Given this list of marker genes MAP3K7, IRAK4, MAPK1, IKBKB, PLCG1, NFKBIA, PELI1, CHUK, TAB2, IL1B (interleukin 1 beta), CCL2, MAP3K3, HSPB2, MAP2K6, MAP3K1, PIK3R2, IRAK2, MAP2K7, MAPK8 (NCBI Gene Id 5599), RELA, MAPK3, MAP2K4, MAPK14, PRKCZ, IL1R1, MAP2K2, JUN, TAB3, PELI2, IL1RAP, AKT1, TRAF6, PTPN11, ECSIT, REL, UBE2V1, MYD88, MAP2K3, SQSTM1, NFKB1, ATF2, IL1A, TOLLIP, UBE2N, TAB1, MAPKAPK2, MAP2K1, IRAK1, MAP3K2, IRAK3, NFKBIB, MAPK9, MAP3K14, IKBKG, PIK3R1, here is a description of the gene set: Human Gene Set: WP_IL1_SIGNALING species: Homo sapiens IL1 signaling